Given this list of marker genes TRH, SLC10A1, UGT1A3 (UDP glucuronosyltransferase family 1 member A3), SLC7A1, SLC32A1, ITGB1, ABCC5, SLCO1C1, MIR33A, PIANP, SFXN5, SLC16A2, SLC26A3, SLC16A3, EPRS1, FABP3, SLC7A5P2, SLC36A4 (solute carrier family 36 member 4), SLC6A9, SLC36A3, DRD4, CYP4F2, SLC25A20, GRM2, SLC7A5, ABCB1, SLC38A10, ACSL1, PROCA1, ABCB11 (ATP binding cassette subfamily B member 11), SLCO1B7, ABCC10, GIPC1, RPS6KB1, SLC38A9, FABP12, SLC1A5, AKT1, PMP2, SLC16A13, SLC7A9, SLC51B, ARL6IP1, SLC6A17, SLC26A11, FOLR2, SLC7A8, SLC22A8, ADORA2A, SLC10A3, CPT1B, SERINC3, SLC2A1, SLC6A1, SFXN1, SLC25A2, LYPLA1, ABCC8, PNPLA8, OXT, SLC11A1, CEACAM1, SLC26A6, SLCO1A2, AVP, SLC22A3, SLC25A38, SLC16A14, SLC22A1, SLC10A4, SLC26A2, NF1, SLC5A12, SLC5A8, ABCC3, SLCO1B1, SLC25A15, SLC1A7, SLC25A32, SLCO3A1, SLC38A8, MPC1L, NR0B2, SLC16A1, SLC1A3, RBP2, ABCC2, ABCD1, PDPN, SLC43A3, ARL6IP5, REPIN1, NOS2, LRRC8A, SLC7A3, FIS1, PLA2G10, SLC16A11, SLC25A1, CROT, DRD2, ABCC4, SLC27A4, SLC1A6, SLC7A7, ABAT, RBP7, SLC16A9 (NCBI Gene Id 220963), SLC35D1, ATP8B1, LRRC8C, KCNK1, FABP7, TRPC4, SLC25A12, SLC10A2, SNCA, LRRC8D, ACE2, SLC43A1, SLC22A2, CLTRN, ACSL5, DRD3, TMEM135, MFSD2A, SLC27A5, PLIN2, DTNBP1, SLC26A5, RGS4 (regulator of G protein signaling 4), ABCD2, BDKRB2, CPT2, ADORA1, FABP6, SLC35D2, CLN3, PSAP, SLC23A1, SLC19A2, FABP1, ANXA1, STXBP1, VPS54, PLA2G12A, SLC22A9, P2RX7, APBA1, SLC6A13, CRABP2, SLC6A15, GOT2, PRKG1, ABCD4, SLC25A10, SLC36A1, PLA2G3, CPT1A (carnitine palmitoyltransferase 1A), SLC38A11, MIF, PLA2G5, SLC43A2, SPX, SLC10A6, IL1B, SLC13A2, SEPTIN2, CASR, CES1, AKR1C1 (aldo-keto reductase family 1 member C1), SLC6A7, LEP (NCBI Gene Id 3952), ACSL4, OC90, SLC66A1LP, SLC25A26 (NCBI Gene Id 115286), PLA2G2A, SLC6A12, SLC26A7, EDN1, SLC26A10P, SLC17A8, ABCG2, SLC25A29, NPY5R, TSPO2, TTYH2 (tweety family member 2), SLC22A7, SLC38A2, PPARG, SLC47A1, TTYH1, SLC7A5P1, SLC25A44, AKT2, GABBR1, PLA2G2F, SLCO1B3-SLCO1B7, SFXN3, PLA2R1, SLC16A12, SLC13A3, SLC10A5, LRRC8E, KCNJ10, SLC27A6, SLC16A4, NMB, FOLR1, EPM2A, SFXN2 (sideroflexin 2), SLC38A6, FGF19, PER2, SELENON, ABCD3, MPC1, SLC25A18, SLC46A1, RBP5, PLA2G2C, SLC16A6, CD36, SLC38A3, SLC1A2, SLC25A17 (NCBI Gene Id 10478), SLC6A8, SLC29A4, SLC17A6, MFSD12, SLC38A5, EMB, CTNS, SLC6A5 (solute carrier family 6 member 5), LRP2, PLA2G4F, SLC38A4, SLC27A3, PLA2G2D, FABP5, PPARA, BEST1, GNAT2, CLDN2, SLC3A1 (NCBI Gene Id 6519), SLC22A13, CLN8 (NCBI Gene Id 619435), PSEN1, SLC16A10, SLC17A7, GJA1 (gap junction protein alpha 1), SLCO2B1, SLCO4A1, PRAF2, KCNK2 (NCBI Gene Id 3776), SLC13A5, SLC26A1, SLCO2A1, IRS2, SLC17A5, ABCB4, SLC25A11, GRM7, ABCC11, AVPR1B, PLA2G12B, ABCC6, TNF, PPARD, CYP7A1, FOLR3, AGXT, THBS1, SLC16A7, SLC27A1, FABP5P3, CACNB4, RAB3GAP1, NMUR2, KCNJ8, PLA2G1B, MPC2, SLC51A, SLCO1B3, SLC38A1, CRABP1, LYN, SLC16A8, APOE, SLC1A1, SLC15A4, SLC6A6, UCP2, SLC26A8, SLC7A13, ABCC1, SLC7A14, NHERF1, SLC3A2, SLC25A22, CYP4A11, SLC22A6, SLC7A6, ATP1A2, FABP4, ERFE, LLGL2, TNFSF11, SYK (NCBI Gene Id 6850), PLA2G4A, GFAP, NFE2L1, SLC6A20, SLC27A2, SLC7A10, SLC7A11, NR1H4, NTSR1, SLC23A2, RGS2, SLC66A1, SYT4, UMOD, PTGES, FABP9, LRRC8B, SLC38A7, SLC7A2, SLC16A5, SLC36A2, NTRK2, PLA2G2E, ACSL3, SLC19A1, SLC5A6, ACACB, AKR1C4 (aldo-keto reductase family 1 member C4), SLC6A11, PTGS2, KMO, TNFRSF11A, P2RX4, SERINC5, SLC1A4, SLC26A4, SLC6A14, GRM1, SLC12A2, TTYH3, SLC22A11, SLC26A9, FABP2, SLC25A13, AVPR1A (NCBI Gene Id 552), ACE, SLC25A21, RBP1, here is a description of the gene set: The directed movement of organic acids, any acidic compound containing carbon in covalent linkage, into, out of or within a cell, or between cells, by means of some agent such as a transporter or pore. Human Gene Set: GOBP_ORGANIC_ACID_TRANSPORT studied in species Homo sapiens